The following is a description of a gene set: Mouse Gene Set: GOBP_REGULATION_OF_TOLL_LIKE_RECEPTOR_4_SIGNALING_PATHWAY Any process that modulates the frequency, rate, or extent of toll-like receptor 4 signaling pathway. species: Mus musculus, and this is the list of marker genes: Hmgb1, Lyn, Ticam2, Ifi35, Mfhas1, Acod1, Znrf1, Nr1d1, Appl2, Lbp, Cd14, Ltf, Sqstm1, Peli1, Dab2ip, F2rl1, Trim32 (tripartite motif-containing 32), Wdfy1, Pik3r1, Rab7b, Appl1, Arf6, Ptpn22, Tirap, Tax1bp1, Ninj1, Nr1h3, Bpifb1, Trem2